The following is a description of a gene set: Catalysis of the reaction: S-adenosyl-L-methionine + histone H3 L-lysine (position 36) = S-adenosyl-L-homocysteine + histone H3 N6-methyl-L-lysine (position 36). This reaction is the addition of a methyl group to the lysine residue at position 36 of the histone H3 protein. Human Gene Set: GOMF_HISTONE_H3K36_METHYLTRANSFERASE_ACTIVITY studied in species Homo sapiens, and this is the list of marker genes: SMYD3, SETD2, SETD3, SETD4, SETD5 (NCBI Gene Id 55209), PRDM9, SMYD2, NSD2, NSD3, SMYD5, SETMAR, NSD1, ASH1L